Given this list of marker genes KDM5A, MLEC, LIAT1, KBTBD4, ZNF579, TBC1D19, ACAD8, SF3A3, ACTG1, POLR3B, SPESP1, LINC02736, GOLGA7, DPY19L4, CDC14A, VARS2, NAXE, OGFOD2, SLC4A1AP, PITX2, CDIPTOSP, DTD2, EMC4, C12orf76, CFAP298, LINC01278, MFSD14CP, HOXC4, MRPL40, EIF3F, JPX, HMGB1, TTI2, SEC23IP, MDM2, DARS2, OCRL, RTEL1, GRAMD1B, EFNB3, DOCK5, ETS1 (ETS proto-oncogene 1, transcription factor), CDIPT (NCBI Gene Id 10423), GLUD1P3, PAXBP1, TMEM106B, TMEM82 (NCBI Gene Id 388595), HNRNPA1, NAPA, LMAN2 (NCBI Gene Id 10960), BMS1P4-AGAP5, CENPL, PCLAF, PSME3, BFSP1, SLC11A2, DNAJC12, SRSF3, INTS12, STX18-AS1, ENSG00000277182, SMG5, RNVU1-27, SLC24A1, SELENOH, DLG2, MTMR9, MTR, ITGB3BP, BMS1P4, NR1H2, PLCXD1, CLASP1, IRF3, PCDH7, HIRA, TOR1AIP1, CFAP298-TCP10L, IPO4, ZKSCAN4, ZUP1, ALDH1A2, COX16, BANF1, MEF2C, MITD1, C17orf75, INTS14, NDUFS7, WDR11-DT, RNVU1-14, FAM186B, PI4K2A, SEC13, RNVU1-30 (RNA, variant U1 small nuclear 30), SF3B6, PLOD2, TMEM79, ZKSCAN8, MIR4521, VIM-AS1, RAMAC, LINC02643, KLHL20, LSG1, MED23, EEIG2, RNF20, CREB5, TVP23B, ZNF566-AS1, TRIP4, MFSD14B, NME1, RPS7, EFCAB7, KLHL5, PIGT, HMGCR, DMBT1L1, CDK16, GTF2H4, ANO8, PDXK, CCDC77, FAM184A, ZNF566, FAM228B, SLC33A1, GGA3, SLC25A18, ALG10, RPL37, MIR6077, EIF4ENIF1 (eukaryotic translation initiation factor 4E nuclear import factor 1), LRRC37A5P, KDELR1, WDR24, DNAJC25-GNG10, EIF5, GABPB2, RNU11, EIF1AD, PAIP1, TMEM242-DT, ADAP2, PPIP5K2, NRTN, KLHDC1 (NCBI Gene Id 122773), ZNF839, SGK1, TUBB4BP7, ENSG00000241525, DPP9, DMAP1, DNAJB7, MPP7, TGS1, TMEM242, GBA1, PHIP, DSTYK, MTCO3P12, MNAT1, TAF6, NUP54, FLT3LG, PDE4B, ABRACL, SHBG, PRKCE (NCBI Gene Id 5581), MRPS31P5, PTPRD-AS1, ATP5PBP7, AP3S2, MAN1B1, ZNF224, PSMB4, EIF4A1, MEGF8, SAT2, PTCH1, LINC02739, NDUFS3, RNVU1-21, ENSG00000237626, SDHAP4, NME1-NME2, MTND5P11, BET1L, ZNF302, ZNF689, ZBTB45, THYN1, SUPT7L, GIN1, DNAJC25 (DnaJ heat shock protein family (Hsp40) member C25), ASAH2B, LTN1, SMG8, CIT, EGFR (NCBI Gene Id 1956), GTF3C5, NCOR2, STX18, DYRK1A, ATP1A1-AS1, GTF3A, ABCB9, AURKAIP1, IRX6 (iroquois homeobox 6), ZNF490, FRA10AC1, MTIF2, ACSM3 (acyl-CoA synthetase medium chain family member 3), HSD17B11, HOMER2, PHACTR1, MRPL44, CEP164P1, POLDIP3, SNX27, RNU5F-1, GTPBP2, PKD2L2, WDR11, TNFRSF10B (TNF receptor superfamily member 10b), MTERF4, ASB5, PCGF2, ABCD3, GRB2, PYGB, DDX55, ATXN2, ZNF791, OSBPL9, ASXL2, ENSG00000214708, UBE2V1, THAP10, LINC00467, TIAM2, TARS2, ITGA2B, TEFM, MAN2C1, PURPL, OSGEPL1, TTK, CGGBP1, STX16, SEPTIN11, OTUD7B, TSPAN10, VPS25, ARIH1, LINC01719, GSTCD, RPSAP75, MORF4L2, SCP2, ATP1B1, TMEM198B, RIC8A, TMEM68, MYLK-AS1, STMN3, C2orf15, NFKBIZ, RCAN1, GTPBP3, VIM, EHBP1, NSA2, RNF181, LINC00412, USPL1, STX16-NPEPL1, LINC00926, LINC01431, NPLOC4, MED18, EPCIP-AS1, R3HDM2, NRCAM, SUCLG1, ZNF227 (NCBI Gene Id 7770), DRG2, MEST, MIR5087, TMEM41A, HNRNPLL, ZNF221, SEC22B, RPS15AP11, HACD2 (3-hydroxyacyl-CoA dehydratase 2), PGAP4, CAPZA2 (NCBI Gene Id 830), ZC3HC1 (zinc finger C3HC-type containing 1), TASOR2, CDC42SE1, NABP2, PLPP3, PPRC1, URI1, ENGASE, CDK5RAP1, BMS1, PIK3CB (phosphatidylinositol-4,5-bisphosphate 3-kinase catalytic subunit beta), MID2, OLFM1, ZKSCAN2, GFM2, SYBU, LRRC49, DNAJC14, RNVU1-3, C3orf38, TIPRL, PDCD6P1, ENPP3 (NCBI Gene Id 5169), CCDC9 (NCBI Gene Id 26093), RTEL1-TNFRSF6B, BCO2 (NCBI Gene Id 83875), MRPL30, VPS51, RNU5A-1, here is a description of the gene set: studied in species Homo sapiens Genes containing one or more binding sites for (ZNF85) in their promoter regions (TSS -1000,+100 bp) as identified by GTRD version 20.06 ChIP-seq harmonization. Human Gene Set: ZNF85_TARGET_GENES from publication Yevshin I, Sharipov R, Kolmykov S, Kondrakhin Y, Kolpakov F (PMID 30445619)